Given this list of marker genes CEPT1, ETNK1, SELENOI, CHKB, ETNK2, PISD, ETNPPL, CHKA, PHOSPHO1, LPIN3, LPIN1, PCYT2, LPIN2, here is a description of the gene set: studied in species Homo sapiens Synthesis of PE Human Gene Set: REACTOME_SYNTHESIS_OF_PE